Given this list of marker genes GAD2, ASPA, AGXT, GAD1, PC, ASS1, GPT, DARS1, GOT2, GOT1, ABAT, ASL (NCBI Gene Id 435), here is a description of the gene set: Human Gene Set: WP_ALANINE_AND_ASPARTATE_METABOLISM studied in species Homo sapiens Alanine and aspartate metabolism